Given this list of marker genes FKBPL, COPS2, ABCA3, JAGN1, ZSWIM7, ACSL6, SLC4A2, GSS, CP, PSMD6, ARAP2, CD1D, PLAAT3, TSPAN3, MYEF2, USB1, JDP2, USP18, FOXK2, KLF3, PIAS4, IMP3, SDC1, KICS2, SNAPC3 (small nuclear RNA activating complex polypeptide 3), PSENEN, RHOT1 (NCBI Gene Id 55288), RCL1, MYOF, MAN1A2, YY1, SMAD1, EXTL1, CYP8B1, UBE2C, NYNRIN, KCNA3, AZIN1, SMPDL3B, IL36G, CYB5R3, ARID5B, CTSK, BCHE, PXK, CLIC3, POU4F3, DENND5A, BCDIN3D, NEU1, TMX1, OCA2, RDH5, RFXAP, ATF4, TOLLIP, SNHG6, ASF1A, SMIM3, UBE2J1, SLC38A2, GFER, KPNA1, BDKRB2, KATNA1, OGT, GALNT6, REEP2, CNOT8, RBM5, PLCZ1, FRMD6, WBP2, IL1RAP, MS4A7, OST4, MAGOHB, ARHGAP6, MDM2 (MDM2 proto-oncogene), FAM184B, SIKE1, UBR4, BOC, CYBA, CMTR1, UBE3A, C18orf32, VAPA, CCT3, RASGRP1, VPS72, WDR20, RAD54L2, QSOX1, BCAM, STMP1, NRP2, OLFM3, TRAF2, SLC28A2, CAPZA1, PSMA4, PPP2R3C, TNNT2, TPR (translocated promoter region, nuclear basket protein), CABLES2, JAK2, PAPSS1, PTPRB, CAMK2D, EXOSC10, AFP, MS4A6A, GABARAPL2, RSRP1, SNAP23, SPATA13, VAMP8, COPG1, PSMD12, ERGIC2, FANCC, BCKDHB, MFSD1, CALCRL, TRIM21, HECTD1, KHDC4, GRIA4, SLC1A3, CKLF, RNGTT, COIL, MITF, GTPBP4, EPHX2, ATOSB, RIOX2, RAB10, EDARADD, RNF185, XYLT2, MAPK6, B3GALT1, FZR1, HP, PFKP, UBXN2A, SEPTIN7, REST, ITGAV, UBXN4, CDC25A, SYPL1 (NCBI Gene Id 6856), COG4, PRPF38A, GGH, AKR1B15, GK, GPR85, SPRYD4, ACTR2, SENP6, VDAC3, ZBTB7A, PUM3, LGALS4, PRDX5, NRBP1, TPRKB, BIK, ZNF503, PHYHIPL, TIMM23, ZC3H12C, EIF4A1, CDC73, ZNF841, CGGBP1, OR51B4, GSTA5, DTNB, TBCEL (tubulin folding cofactor E like), TLK2, HPS3, ANKIB1, FBXO4, TMEM168, ACSM1, PPP1R11, RELA, KAT2B, VTI1A, TLR8, EMC4, TXN, UBE2W, CBFB, ACRV1, RABEP1, here is a description of the gene set: studied in species Homo sapiens from publication Amit I, Garber M, Chevrier N, Leite AP, Donner Y, Eisenhaure T, Guttman M, Grenier JK, Li W, Zuk O, Schubert LA, Birditt B, Shay T, Goren A, Zhang X, Smith Z, Deering R, McDonald RC, Cabili M, Bernstein BE, Rinn JL, Meissner A, Root DE, Hacohen N, Regev A (PMID 19729616) mouse primary BMDCs were stimulated with tlr ligands and gene expression changes were profiled on Affymetrix arrays Human Gene Set: GSE17721_0.5H_VS_8H_PAM3CSK4_BMDC_DN Genes down-regulated in comparison of dendritic cells (DC) stimulated with Pam3Csk4 (TLR1/2 agonist) at 0.5 h versus those stimulated at 8 h.